The following is a description of a gene set: from publication Cui A, Huang T, Li S, Ma A, Pérez JL, Sander C, Keskin DB, Wu CJ, Fraenkel E, Hacohen N (PMID 38057668) Mouse Gene Set: CUI_B_CELL_IFNB_RESPONSE_DN species: Mus musculus Genes negatively differentially expressed in cell type: B cell upon treatment with cytokine: IFN-β in mouse lymph nodes in vivo. Cytokines mediate cell-cell communication in the immune system and represent important therapeutic targets. A myriad of studies have highlighted their central role in immune function, yet we lack a global view of the cellular responses of each immune cell type to each cytokine. To address this gap, the authors created the Immune Dictionary, a compendium of single-cell transcriptomic profiles of more than 17 immune cell types in response to each of 86 cytokines (>1,400 cytokine-cell type combinations) in mouse lymph nodes in vivo. A cytokine-centric view of the dictionary revealed that most cytokines induce highly cell-type-specific responses. For example, the inflammatory cytokine interleukin-1β induces distinct gene programmes in almost every cell type. A cell-type-centric view of the dictionary identified more than 66 cytokine-driven cellular polarization states across immune cell types, including previously uncharacterized states such as an interleukin-18-induced polyfunctional natural killer cell state., and this is the list of marker genes: Ddx5, Add3, Klf2, Chst3, Coro1a, Lbh, Fxyd5, Man1a, Zfp36, Tnfrsf13b, Smad7, Pde7a, Prdx5, Eif3f, Pou2f2, Gga2, Ier5, Myh9, Ralgps2, Stap1, Dnm2 (dynamin 2), Gnas, Higd2a, S100a10, Ikzf3, Cr2, H2-DMb2, Siglecg, Fau, Uqcrh, Gnai2, Nap1l1, Aup1, Fcrla, Ptp4a3, Cd22, Acp5, Neurl3, Arhgap4, Cd200, Lcp1, Cox7a2l, Gimap3, Limd2, Tspan13, Rasgrp2, Ciita (NCBI Gene Id 669998), Kctd12, Iglc2, Cnn2, Cxcr4, Cst3 (NCBI Gene Id 13010), Ptpn18 (NCBI Gene Id 19253), Cyba, Cd52, Tcp11l2, Foxp1, Stk17b (serine/threonine kinase 17b (apoptosis-inducing)), Grk6, Cyp4f18, Aldh2 (aldehyde dehydrogenase 2, mitochondrial), Cd81, Marchf1, Mical1, Fam107b, Gpx4, Mef2c, Tgfbr2, Foxn3, Grap2, Pbxip1, H2-Ob, Calm1, Uba52, Cyth4 (NCBI Gene Id 72318), Smim14, Klhl24, Ralbp1, Ikbkb, Hexb, S100a11, Ighm, Cd37, Gpx1, Dnase2a, Parp1, Pglyrp1, Syk, Lamtor2, Top2b, Lsp1, Ets1, Cap1, Emp3, Ccr7, Il16 (interleukin 16), Gabarap, Rabgap1l, Arhgap45, Cotl1, Ftl1, Gsn, Dok3, Actg1, Cmah, Cd79a, Gpsm3, H2az2, H3f3a, Malt1, Ebf1, Gimap6, Hvcn1, H2-Eb1, Mif4gd, Txnip, Btk, Pnrc1, Sh3bp5, Ypel3, Ddx17, Gm2a, Tspan32, Bank1, St8sia4, Map4k4, Arhgdib, Fosb, H2-Aa (NCBI Gene Id 406213), Ptp4a2, Grap, Tmem108, Crip1 (cysteine-rich protein 1), Fcer2a, Dpm3, Map3k1, Trim7, Ttpal, Btg1, Sh3bgrl3, Ucp2, Arhgef18, Tsc22d4, Acap1, Ccr6 (C-C motif chemokine receptor 6), Satb1, Ubl3, Pgap1, Tle5, Ripor2, Vpreb3, Cd24a, Cd74, Cyb5a, Ogt, Macf1, Cd55, H1f2 (NCBI Gene Id 68317), Cd79b, Irag2, H2-DMa, Rac2 (Rac family small GTPase 2), Iglc3, Cdc42se2, Chchd10, Wasf2, Pold4, Slc38a1, Kif21b, Fth1, Phf3, Sgms1, Dennd5b, Tmem234, H2-Ab1, Pfdn5, Gmfg, Snx29, Prcp, Kmt2e, Myl6, AB124611, Arid5b, Tbc1d10c, Trim5